The following is a description of a gene set: Mouse Gene Set: GOMF_COENZYME_A_DIPHOSPHATASE_ACTIVITY Catalysis of the reaction: an acyl-coenzyme A or its derivatives + H2O = adenosine 3',5'-bisphosphate + an acyl-4'-phosphopantetheine + 2 H+. This reaction can also use coenzyme A as a substrate. studied in species Mus musculus, and this is the list of marker genes: Nudt19, Fitm2, Enpp1, Fitm1, Nudt8, Nudt7